Given this list of marker genes Hoxb2, Hoxb1, Nrp2, Kcna2, Dmd, Pax2, Nrp1, Sema3a, Egr2, Sema3f, Plxna4, Hoxa1, Plxna3, here is a description of the gene set: species: Mus musculus The process that contributes to the act of creating the structural organization of the cranial nerves. This process pertains to the physical shaping of a rudimentary structure. The cranial nerves are composed of twelve pairs of nerves that emanate from the nervous tissue of the hindbrain. These nerves are sensory, motor, or mixed in nature, and provide the motor and general sensory innervation of the head, neck and viscera. They mediate vision, hearing, olfaction and taste and carry the parasympathetic innervation of the autonomic ganglia that control visceral functions. Mouse Gene Set: GOBP_CRANIAL_NERVE_STRUCTURAL_ORGANIZATION